Given this list of marker genes TBCB, HSP90B1, COPB2, PSMD9, COPZ1, PDIA3, TRAPPC6B, PSMD4, ASNS, SAR1A, SELENOS, PSMD2, PRSS16, PSMB4, SAR1B, SEC22B, YIPF5, PDIA4, PPP1R15A, ADCY3, GOLM1, TMED7, POMP, COPG1, GOSR2, PSMB1, YIPF1, PSMB3, COPE, TRAPPC3, PSMD3, PSMA8, TXNDC12, B2M, PSMD1 (proteasome 26S subunit, non-ATPase 1), ERGIC3, PSMD13, KDELR2, TRAPPC6A, PSMC4, ERGIC1, GOLPH3L, CBY1, TMED10, PSMD6, TRAPPC1, TMED9, BCAP31, COPB1 (COPI coat complex subunit beta 1), GOPC, COPG2 (NCBI Gene Id 80038), BCAP29, SIL1, HSPA5, SEC22A, COPA, PSMA5, CALR, WFS1, DDIT3, HERPUD1, PSMB7, PSMD10, TRAPPC4, here is a description of the gene set: studied in species Homo sapiens Antigen processing and presentation genes up-regulated in JY cells (B lymphocytes) treated with TSA. Human Gene Set: PELLICCIOTTA_HDAC_IN_ANTIGEN_PRESENTATION_UP from publication Pellicciotta I, Cortez-Gonzalez X, Sasik R, Reiter Y, Hardiman G, Langlade-Demoyen P, Zanetti M (PMID 18829567) Histone deacetylases (HDAC) modify the architecture of chromatin, leading to decreased gene expression, an effect that is reversed by HDAC inhibition. The balance between deacetylation and acetylation is central to many biological events including the regulation of cell proliferation and cancer but also the differentiation of immune T cells. The effects of HDAC inhibition on the interaction between antitumor effector T cells and tumor cells are not known. Here, we studied presentation of a universal self-tumor antigen, telomerase reverse transcriptase, in human tumor cells during HDAC inhibition. We found that HDAC inhibition with trichostatin A was associated with a decreased presentation and diminished killing of tumor cells by CTLs. Using gene array analysis, we found that HDAC inhibition resulted in a decrease of genes coding for proteasome catalytic proteins and for tapasin, an endoplasmic reticulum resident protein involved in the MHC class I pathway of endogenous antigen presentation. Our findings indicate that epigenetic changes in tumor cells decrease self-tumor antigen presentation and contribute to reduced recognition and killing of tumor cells by cytotoxic T lymphocytes. This mechanism could contribute to tumor escape from immune surveillance.